Given this list of marker genes FDX1, DUSP1, CD55, STAR, VEGFA, GDE1, MT2A, here is a description of the gene set: Genes up-regulated in rFSH-17 cells (primary granulosa) after stimulation with FSH. from publication Sasson R, Dantes A, Tajima K, Amsterdam A (PMID 12832290) Human Gene Set: SASSON_FSH_RESPONSE studied in species Rattus norvegicus Follicle-stimulating hormone (FSH) controls the development of follicle-enclosed oocytes in the mammalian ovary by interacting with specific receptors located exclusively on granulosa cells. Its biological activity involves stimulation of intercellular communication, intracellular signaling, and up-regulation of steroidogenesis; the entire spectrum of genes regulated by FSH is not yet fully characterized. We have established monoclonal rat FSH-responsive granulosa cell lines that express FSH receptors at 20-fold higher rates than with primary cells, and thus increased the probability of yielding a distinct spectrum of genes modulated by FSH. Using Affymetrix DNA microarrays, we discovered genes not reported earlier to be up-regulated by FSH and genes not reported earlier to be down-regulated by FSH. Modulation of signal transduction associated with G-protein signaling, phosphorylation of proteins, and intracellular-extracellular ion balance was suggested by up-regulation of decay accelerating factor GPI-form precursor (DAF), membrane interacting protein RGS16, protein tyrosine phosphatase (PTPase), oxidative stress-inducible protein tyrosine phosphatase (OSIPTPase), and down-regulation of rat prostatic acid phosphatase (rPAP), Na+, K+-ATPase, and protein phosphatase 1beta. Elevation in granzyme-like proteins 1 and 3, and natural killer (NK) cell protease 1 (NKP-1) along with reduction in carboxypeptidase E indicates possible FSH-mediated preparation of the cells for apoptosis. Up-regulation of vascular endothelial growth factors indicates the ability of FSH to produce angiogenic factors upon their maturation; whereas, reduction in insulin-like growth factor binding protein (IGFBP3) indicates its increased potential to promote p53-induced apoptosis. Striking similarities in FSH modulation of gene expression were found in primary cultures of human granulosa cells obtained from IVF patients although these cells expressed only 1% of FSH receptor compared with immortalized rat cells, as indicated by microarray technique, which probably is in the normal range of expression of this receptor in nontransformed cells. These findings should increase our understanding of the mechanism of FSH action in stimulating development of the ovarian follicular cells, of intracellular and intercellular communication, and of increasing the potential of ovarian follicular cells to undergo apoptosis during the process of selection of the dominant follicle.